Given this list of marker genes SNN, DUSP1, CCDC91, AATF, TSPAN8, SCAND1, C1orf159, MRPS15, SEC23B, APP, PCSK6, EFS, UGDH, STK16, BRWD1, NIF3L1, CDH17, UBA1, WDR81 (NCBI Gene Id 780925), LONP2, ACTG1, OSBP, TRIB1, ATXN7L1, ABCC9, ATG16L1, LRP1, ACLY, ANGPTL6, U2SURP, ACSL5, COX18, SNAP47, TMED10, RGS9, MTX1, DUSP19, TTR, INTS11, PARP3, PITX3, GUCA2B, RFX1, FNTA, DLG1, ARF1, ITIH5, SSR3, SLC10A3, CACNA1H, ELMO2, FSTL1, DNAH8, STK19, RECQL, NIT1, HAUS2, VEGFB, H1-10, MRPL9 (NCBI Gene Id 65005), MAPKAPK5, AGGF1, RARB (NCBI Gene Id 5915), NEPRO, SEMA3E, UBE4A, SULF2, IGDCC3, PNPO, TMEM114, SFRP1, OGN, QNG1, TTLL3, CENPV, SF1, FZD9, CLASRP, SLC9A8, DPEP3, CACHD1, GMPPB, DIAPH2, GARS1, SDHB, CRLF1, TFB1M, ZNHIT2, CTBP1, EIF2B5, FTO, HLX, FAM50A, P4HA2, GATB, F7, APBA3, METAP2, AQP7, AP1M1, GLI1, DLST, NKIRAS1, CPT1A, ATXN1, PDCD2, YWHAG, IGDCC4, VANGL2, GAST, ZNF622, CHID1, FHOD3, RARS2, MYO1F, RBMXL1, COL4A5, NDP, TIAM2, TANGO2, PAICS, GRM8, MOS, NUDT19, NDUFS2, PIP4K2C (NCBI Gene Id 79837), ALG9, IL1R1, POF1B, TCAP, PLBD1, DYNLL1, RAB3GAP2, NFATC2IP (NCBI Gene Id 84901), LCP1, SIDT2, PAPSS2, H19, POLR2M, VPS45, CDC6, STK10, DNMT3A, PES1, SIVA1, KCNAB3, WDR12 (WD repeat domain 12), RPL36A, EMC8, PNPT1, TFF2, NF2, GFI1B, TEFM, SLC24A1 (solute carrier family 24 member 1), RSL24D1, NUFIP1, BTG3, KMT5B, OPN3, SOAT1, MAP4K1, MRPS16, RING1, PPP1R21, LYZL1, ZFYVE19, SSX5, WNT9A, MYO7A, KCNK1, MAZ, UBFD1, MFN2, PGP, SPRR3, TYRP1, CTDP1, CCR1, RRAGD, SEMA4G, ARRB1, CNTN6, TMEM185A, KRTCAP2, STRA6 (NCBI Gene Id 64220), B9D2, NCMAP, MCM2, KLF7, NSG2, PLOD3, MRPS23, KIF5C, NUDCD1 (NCBI Gene Id 84955), PTCRA, LRRIQ4, UFSP1, IPO5, TAF10, here is a description of the gene set: Genes up-regulated in comparison of dendritic cells (DC) stimulated with Pam3Csk4 (TLR1/2 agonist) at 1 h versus DC cells stimulated with CpG DNA (TLR9 agonist) at 1 h. Human Gene Set: GSE17721_PAM3CSK4_VS_CPG_1H_BMDC_UP from publication Amit I, Garber M, Chevrier N, Leite AP, Donner Y, Eisenhaure T, Guttman M, Grenier JK, Li W, Zuk O, Schubert LA, Birditt B, Shay T, Goren A, Zhang X, Smith Z, Deering R, McDonald RC, Cabili M, Bernstein BE, Rinn JL, Meissner A, Root DE, Hacohen N, Regev A (PMID 19729616) mouse primary BMDCs were stimulated with tlr ligands and gene expression changes were profiled on Affymetrix arrays studied in species Homo sapiens